The following is a description of a gene set: studied in species Homo sapiens Abnormal change in social behavior Human Gene Set: HP_ABNORMAL_CHANGE_IN_SOCIAL_BEHAVIOR An alternation in the habits and emotional tendencies of an individual with a change in behavior that is typically noticed by family members or peers., and this is the list of marker genes: ATP7B (NCBI Gene Id 540), EIF4A2, PTRHD1, GRN, TDO2, TRANK1